Given this list of marker genes Bcl2l1 (NCBI Gene Id 12048), Cpeb1, Hmgcs2, Mir346, Mir203, Mir92-2, Mir24-2, Mir1897, Col1a2, Col4a1, Vegfa, Col3a1, Sesn3, Mir667, Mir495, Pik3ca, Socs1, Mir216b, Anxa2, Mir27a, S100a10, Mir15b, Mtor, Mir199a-2, Avpr1a, Mir429, Mir421, Mir30a, Lamtor1, Mir224, Mir377, Nfe2l2, Glra2, Prkn, Rptor, Eno1, Slc7a5, Lamtor5, Mir1894, Mir34a (microRNA 34a), Sesn1, Mir134, Hsf1, Mir221, Mir486, Mir151, Col1a1, Nsmf, Cpeb4, Castor2, Ubr2, Mir1948, Mir31, Mir544, Cul3, Mir217, Mirlet7f-2, Slc38a9, Abcb1a, Col6a1, Mir30e (NCBI Gene Id 723836), Mir802, Mir155 (microRNA 155), Prmt1, Dnmt1, Ntrk2 (NCBI Gene Id 77471), Mir3072, Gria2, Gclc, Neurl1a, Mmp2, Mir466f-1 (NCBI Gene Id 100124486), Col16a1, Mir466g, Mir669f, Mir145a, Mir466f-2, Bmt2 (base methyltransferase of 25S rRNA 2), Mir122, Mmp3, Mir214, Mir222, Mir301, Cpeb3, Mir107, Cybb, Mir382, Klf2, Tnf, Mir466f-4, Mir487b, Cebpb, Cdh1 (NCBI Gene Id 12550), Klhl22, Mirlet7a-2, Mir1224, Mir666, Zeb1, Sipa1, Mir466i, Mir674, Mir376b, Rragd, Mir192, Mir92b, Grin3b, Mir103-1, Sesn2, Mirlet7d (NCBI Gene Id 387247), Lars1, Mir669c, Mir378a, Mir150, Mir466f-3, Mir762, Dnmt3b, Mir376c, Mirlet7i, Egfr, Gclm, Mir194-1, Dnmt3a, Mir409, Grin2a, Mir455, Plec, Lmnb1, Six1, Mir99a, Lamtor2, Mir103-2, Agap2, Stambpl1, Rraga, Rbx1-ps, Mir676, Pdgfc, Mir101b, Glra3, Xbp1, Ptgs2, Aqp2, Ubr1 (ubiquitin protein ligase E3 component n-recognin 1), Mir154, Col5a2, Mir1983, Bcl2l2, Bdnf (NCBI Gene Id 12064), Mir376a, H2bc1, Mir369 (NCBI Gene Id 723933), Mat2a, Lamtor3, Rragb, Mir191, Mir101a, Col4a6, Fyn (NCBI Gene Id 14360), Mir15a, Glra1, Atp7a, Pkd2, Ass1 (argininosuccinate synthetase 1), Pdgfd, Mir23a, Mir872, Mir199a-1, Mir543, Sh3bp4, Mir539, Lamtor4, Mir29c, Mir451a, Mir200b, Mir351, Npas4 (neuronal PAS domain protein 4), Capn2, Mir365-2, Mir425 (NCBI Gene Id 723864), Mir200c, Mir365-1, Spaar, Ipo5, Mirlet7a-1, Mir496a, Mir137, Hpca, Mir342, Mir130a, Mir194-2, Mir22, Mir466j, Baiap2, Gria1, Pdgfra, Rbx1, Castor1, Hnf1a, Mir193a, Mirlet7f-1, Amigo1, Mir379, Mir708, Mir92-1, Ep300, Mir654, Ngf, Mir183, Hnrnpd, Grin2d, Mir30d, Mir466h, here is a description of the gene set: Mouse Gene Set: GOBP_CELLULAR_RESPONSE_TO_ACID_CHEMICAL Any process that results in a change in state or activity of a cell (in terms of movement, secretion, enzyme production, gene expression, etc.) as a result of a stimulus by the chemical structure of the anion portion of the dissociated acid (rather than the acid acting as a proton donor). The acid chemical may be in gaseous, liquid or solid form. species: Mus musculus